The following is a description of a gene set: Genes positively correlated with amplifications of MYCN in the SCLC (small cell lung cancer) cell lines. Human Gene Set: KIM_MYCN_AMPLIFICATION_TARGETS_UP species: Homo sapiens DNA amplifications and deletions frequently contribute to the development and progression of lung cancer. To identify such novel alterations in small cell lung cancer (SCLC), we performed comparative genomic hybridization on a set of 24 SCLC cell lines, using cDNA microarrays representing approximately 22,000 human genes (providing an average mapping resolution of <70 kb). We identified localized DNA amplifications corresponding to oncogenes known to be amplified in SCLC, including MYC (8q24), MYCN (2p24) and MYCL1 (1p34). Additional highly localized DNA amplifications suggested candidate oncogenes not previously identified as amplified in SCLC, including the antiapoptotic genes TNFRSF4 (1p36), DAD1 (14q11), BCL2L1 (20q11) and BCL2L2 (14q11). Likewise, newly discovered PCR-validated homozygous deletions suggested candidate tumor-suppressor genes, including the proapoptotic genes MAPK10 (4q21) and TNFRSF6 (10q23). To characterize the effect of DNA amplification on gene expression patterns, we performed expression profiling using the same microarray platform. Among our findings, we identified sets of genes whose expression correlated with MYC, MYCN or MYCL1 amplification, with surprisingly little overlap among gene sets. While both MYC and MYCN amplification were associated with increased and decreased expression of known MYC upregulated and downregulated targets, respectively, MYCL1 amplification was associated only with the latter. Our findings support a role of altered apoptotic balance in the pathogenesis of SCLC, and suggest that MYC family genes might affect oncogenesis through distinct sets of targets, in particular implicating the importance of transcriptional repression. from publication Kim YH, Girard L, Giacomini CP, Wang P, Hernandez-Boussard T, Tibshirani R, Minna JD, Pollack JR (PMID 16116477), and this is the list of marker genes: SCFD2, ST8SIA1, MACF1, PRSS12, F11, CDR1, ZSWIM6, DIPK1B, HYPK, NME1, LRP4, POP1, MMRN1, GRK3, DGKZ, PHKA1, TSHZ1, RARG, GNAZ, RPIA, PAG1, ADCY9, FANCC, INSL3, HSPA4L, CREB3L4, CLPS, TUB, PDE2A, MIR17HG, NMNAT2, P2RY1, IER5, SHC3, L3MBTL4, CA13, HS6ST3, UCK2 (uridine-cytidine kinase 2), PPM1K, KLHDC7A, FAM81A, ZNRF3, ANGPTL2, DDX1, NECAB1, COMP, TENM2, APH1A, DICER1, SLC25A33, ETFA, ERBB3, DIO3, ZDHHC2, FAM241A, ENO1, MYO1E, SLC44A1, STK39, UNG, SLC1A2, ABCA8, DRD2, HADH, PRRG1, AKR1B1, RAB33A, CAMK4, LILRA1, PRDX4, GREM1, IMP4, SESN3, RGL1, MNX1, ADARB1, BCAT1, SFI1, RPP25, STAMBPL1, SYNPO, BTC, CLYBL, HIGD1A, IRAG2, PDZRN3 (PDZ domain containing ring finger 3, NCBI Gene Id 23024), PITX2, MYCN, AP1S2, GPR27, PTDSS1, SLC6A15, FCER1A